The following is a description of a gene set: Catalysis of an oxidation-reduction (redox) reaction in which a heme group acts as a hydrogen or electron donor and reduces a hydrogen or electron acceptor. species: Homo sapiens Human Gene Set: GOMF_OXIDOREDUCTASE_ACTIVITY_ACTING_ON_A_HEME_GROUP_OF_DONORS, and this is the list of marker genes: MTCO2P12, COX6B1, COX4I1, MT-CO2, COX7A2L, MT-CO1, SURF1, CYGB, COX7A1, POR, MT-CO3, COX5A, COX7B, COX5B, COX8A